The following is a description of a gene set: Adherens junctions depend on formation of dimers between extracellular domains of cadherins presented on the surface of neighboring apposed cells, bridging the intermembrane space. The cadherin dimers are stabilized by interaction of intracellular domains of cadherins with cytoplasmic catenins that further associate with cytoskeletal proteins, such as actin and microtubules. The dimers are largely homotypic (homophilic), involving identical cadherin proteins, but heterotypic (heterophilic) interactions, involving different cadherin proteins, also occur. Heterotypic cadherin interactions contribute to formation of asymmetric adherens junctions which may serve to sense differences in cytoskeletal geometry between neighboring cells during development. One mechanism for regulation of homotypic cell-cell adhesion is the regulation of expression of cadherin genes. For review, refer to Yap et al. 1997, Meng and Takeichi 2009, Brasch et al. 2012, Malinova and Huveneers 2018).<br><br>Cadherins are a family of evolutionarily conserved calcium-dependent single-pass transmembrane proteins characterized by the presence of an N-terminal ectodomain composed of tandem extracellular cadherin (EC) repeats that engage in extracellular interactions mediating cell-cell adhesion through dimerization, and a C-terminal cytoplasmic tail that interacts with catenins and links extracellular adhesion to the cytoskeleton. Based on their sequence similarity, cadherins can be grouped into type I classical cadherins, type II classical cadherins, clustered and non-clustered protocadherins, 7D cadherins, and CELSR cadherins; CDH13 and CDH26 have not been grouped so far. Type I and II classical cadherins are comprised of five extracellular cadherin (EC) repeats in their ectodomains. The first, membrane distal cadherin repeat (EC1) of type I classical cadherins possesses a conserved tryptophan residue at position 2, while the EC1 of type II classical cadherins has two conserved tryptophan residues, at positions 2 and 4. The conserved tryptophan residues are involved in dimerization. 7D cadherins have 7 cadherin repeats in their ectodomains and a conserved tryptophan residue in the third cadherin repeat. CELSR cadherins possess 6-9 cadherin repeats in their ectodomains and no conserved tryptophan residues. Calcium ions bind to cadherins at conserved sites in between consecutive EC repeats, commonly each site binding three calcium ions (Ca2+), and plays an important role in formation of strand-swapped trans dimers in classical cadherins, and protein rigidity in others. For review, refer to Brasch et al. 2012, Gul et al. 2017. part of: Adherens junctions interactions species: Homo sapiens Reactome Pathway: Regulation of Homotypic Cell-Cell Adhesion, and this is the list of marker genes: SPCS1, FOXF1, CTSS, HOXC8, CDH8, MOGS, ADRM1, TWIST2, FYN, MIR451A, ADAM19 (NCBI Gene Id 8728), RBBP4 (NCBI Gene Id 91125), UBC, MTBP, PIP5K1C, H2BC4, MDM2, SIRT1, PSMD8 (NCBI Gene Id 5714), H2BC1, KLF4, PSMB7, WT1, TNRC6A, MIR9-2, PSMC5, H2AC20, STT3A, PSMD3, H2BC12L, CDH19, RPS27A, SMARCA4, PSMB1, H2BC17, PSMD11, H2BC11, AGO1, CANX, CTNNA1, VCL, FOXA2, H2AB1 (NCBI Gene Id 474382), H2BC3, PSMB5, CTNNB1, FOXQ1, ACTG2, MIR10B, PRDM8, MPHOSPH8 (NCBI Gene Id 54737), GANAB, H2AC14, MAPK3, SUZ12, RB1, H2BC26, TCF3, PSMB6, RPN2, ILF3 (NCBI Gene Id 54783), MIR200C, H3C15, PSMA5, CSNK2A2, H2BC12, HEYL, TWIST1, ADAM33, KMT5A (NCBI Gene Id 387893), KDM1A, H2BC5, PSMA1, H2BC13, MAPK1, PCSK6, PSMA3, PSMB2, PCSK7, DNM2, PSMC4, H2AZ2 (H2A.Z variant histone 2), PSMD14, DNTTIP1, H2AC4, HDAC1 (histone deacetylase 1), CTSB (NCBI Gene Id 3896), FOXP2, PSMC3, H2AC6, AGO2, OSTC, ZNF217, TLE1, AMOT, STRAP, TGIF2, PSMD1, PSMC2, PSMD7, SNAI1, H2BC21, PSMD2 (NCBI Gene Id 5708), ACTC1, MOV10, DDOST, DAD1, ZMYM2, ZBTB33, PRKCSH, ARHGAP32, PSMA2, PSMC1, RACK1, TCF12, PSMC6, ACTA2, CDH1, POMT2, CDH11, UBB, PSMA7, CTBP1, FURIN, BANP, CTNND1, H4C1, PSMA4, CSNK2A3, TFAP2A, MYCN, RBBP7, ANGPTL4, ZC3H12A, PSMD6, PSMA6, CDH24, H2BC14, ZEB2, SRC, CTSL, H2AX, SEC11A, CSNK2B, KLF9, ACTG1, TNRC6B, H3-3A (H3.3 histone A), SPCS2 (signal peptidase complex subunit 2), FOXJ2 (forkhead box J2), EED, OST4, SPCS3, RPN1, BHLHE22, UCA1, SNAI2, H2AC18, EPS15, PSMD12, CSNK2A1, PSMB4, SP1, MIR9-1, UBA52, CBLL1, EZH2, MYC, POMT1, H2AJ, PSMD13, H2BC15, ACTA1, HDAC2, ACTB, JUP, PKM, ANK3, SEC11C, AGO4, ARID1A (AT-rich interaction domain 1A), TMEM258, CTBP2, H2BC9, SOX10, ZEB1, PSMB3, SEM1, H2AC7, TNRC6C, MIR9-3, MCRIP1 (MAPK regulated corepressor interacting protein 1), H3C1, AGO3